The following is a description of a gene set: from publication Chen Y, Wang X (PMID 31504780) Human Gene Set: MIR12132 studied in species Homo sapiens Genes predicted to be targets of miRBase v22 microRNA hsa-miR-12132 in miRDB v6.0 with MirTarget v4 prediction scores > 80 (high confidence targets)., and this is the list of marker genes: CLIC1, TAF4, BASP1, ZNF587, XPA, DAAM1, SEPTIN11, FAM120A, ZBTB21, C1GALT1C1L, LRCH2, PSIP1, DDX5 (DEAD-box helicase 5), LANCL3, NAB1, SSBP2 (NCBI Gene Id 51492), SALL3, NPLOC4, BAG2, LYPLAL1, RAB6A, MAP4K3, PCDH8, CBFB, ARHGAP5, CSF2, PTPN13, FANCC, EIF3J, ZNF621, OTULIN, CCDC186 (NCBI Gene Id 55088), ASB4, WDR17, TMEM117, VAPB, CLDN7, VCPIP1, ZNF417, MAP3K20, TLK1, UNC119B, HOOK1, KAT6A, SMAP1, PDLIM5, KLHL15, SACM1L, IDI2, PRR3, CRH, SUGT1, LRRC8D, ADAMTS6 (ADAM metallopeptidase with thrombospondin type 1 motif 6), ZSCAN16, C1GALT1, POC1B, SMARCA4, NTN4, UTP11, WWP1, CAPZA1 (NCBI Gene Id 829), SMG7, ELOVL5, PGM2L1, APOL6 (NCBI Gene Id 80830), TOMM20L, TMEM254, SALL1, PTPRR, ZNF45, GPM6A, FBXW2, OLFM3, LSM8, HNRNPLL, DSG2 (desmoglein 2), GRHL3, GPATCH2, POU1F1, MON2, ERMP1, FBN2, COL23A1, SREK1 (splicing regulatory glutamic acid and lysine rich protein 1), GSPT2, RNF111, SETMAR, CLOCK, SPOPL, RPL34, VPS29, MRPS5, ASB8, APC, DACT1 (NCBI Gene Id 51339), ASAP2, MAFB, ANKRD13C, C6orf58, ZFP2, VPS13C, DISC1, NRN1, CYP39A1, SH3D19, DISP2, RHNO1, PPEF1, KLHL11, QSOX2, PABPC5, TRHDE, SNX2, TRAK2, IFT70B, VAMP4, GPBP1L1, MED14, ALG10, MAB21L2, GLRB, BTF3L4, WASL, TASP1, YIPF4, HIPK1, LONP2, EVL, RAPGEF4, CTCF, HS2ST1, CNR1, SLC6A13, PLCXD3, IRF8, SEPHS1, ARSB, SYS1, PRH2, SYT1, CNOT7, PTPN21, RPL39, SP4 (NCBI Gene Id 6671), ZNF444 (zinc finger protein 444), CIB1